The following is a description of a gene set: Genes predicted to be targets of miRBase v22 microRNA hsa-miR-548ai, hsa-miR-570-5p in miRDB v6.0 with MirTarget v4 prediction scores > 80 (high confidence targets). species: Homo sapiens Human Gene Set: MIR548AI_MIR570_5P from publication Chen Y, Wang X (PMID 31504780), and this is the list of marker genes: PSMD7, SETD9, EPHB1 (EPH receptor B1), TCERG1, CYP2J2, PWWP2A, SP110, GNG12, CHL1, PRDM4, ELOVL5, SVIL, RDX, ZHX2, TMEM229A, GABARAPL1 (GABA type A receptor associated protein like 1), PABPC5, CDH19 (cadherin 19), FBXL4, ENSG00000275895, MTUS1, SASS6, CEP97, RHOA, HSPA4L, TNKS2, SON (SON DNA and RNA binding protein), SLC25A12, POLR3G, TRIM13, PIK3C2B, FIP1L1, MOB1B, C4orf46 (NCBI Gene Id 201725), PF4, GALNT7, ZNF730, STAM, PSME3, PURB, OBSL1, PDHA1, COG5, PWP1, BMP3, ZNF362, U2AF1, LPP, B3GNT5, ENPP4, BCAT1, CMTM4, DCP2, RBMXL3, LMBR1, SPDYE1, SPCS3, OIP5, IFIT1B, PKD2, TNIK, MFN1, TMEM200A, INSIG1, COX5A, KRTAP9-9, ITSN1, DCAKD, APPBP2, TMPRSS11B, BICD2, RGS9BP, ZNF699, DIXDC1, TOMM5 (translocase of outer mitochondrial membrane 5), RREB1, GUCY1A2, SLC17A6, PSMA8, KDM2B, MAP7, IQCK, HELQ, C1orf115, GASK1B, MORC3, ULK2, TCFL5 (NCBI Gene Id 10732), EPSTI1, VAPA, PDE7A, PDLIM5, LCOR, PCMTD1, ZC2HC1C, PAK2, TPR, CDC14A, SMAD2, TMEM178B, STXBP1, STAU2, CAMSAP2, USP42, LSM8, SPDYE3, UBE2W, SEMA3C, BRMS1L, ANKRD13A, EFEMP1, DICER1, MRO, ITPR3, CERT1, MBNL3, ZNF43, PCDH18, PCDH15, CCDC43, RIOX1, NELL2, C21orf91, NFE2L3, ZNF777, RFXAP, GPM6A, SLC19A2, LAMTOR5, PDE6C, ANKRD17, SPDYE5, NEK2 (NIMA related kinase 2), SPDYE6, HPCAL4, MPRIP, CRISPLD1, DENND4C, CEP78, WDR20, NEUROD1, TRIP11, EHBP1, TYMSOS, NEMP1, ZNF461, ZNF716, DENND1A, BACH2 (NCBI Gene Id 653980), ZDHHC21, SLC15A1, NFYB, ZEB2, RORB, NCKAP1, RNF38, P2RY12, CRNKL1, PPP3R1, AMER2, RGL1, HMCN1, RWDD4, OTUD6B, GDNF, QKI, UBE2E3, ZNF770, TNRC6C, CENPK, ZNF585B (zinc finger protein 585B), CD164